The following is a description of a gene set: Human Gene Set: WP_PEPTIDE_GPCRS Peptide GPCRs species: Homo sapiens, and this is the list of marker genes: SSTR3, GALR3, CXCR2, AGTR2, OPRL1, TSHR, NTSR2, FPR1, MC5R, CCR8, GRPR, AVPR1B, MC3R, GNRHR, MC1R, CCKBR, NPY2R, CXCR3, AVPR1A, CCR7, TACR3, HCRTR1, C5AR1, SSTR2, CCR6, BDKRB2, AVPR2, FPR3, NPY5R, OXTR, CCR5, CXCR1, ACKR1, TACR2, LHCGR, BRS3, CCR1, NMBR, OPRM1, TRHR, OPRK1, FPR2, OPRD1, SSTR1, CCKAR, TACR1, EDNRA, NPY1R, CCR10, SSTR5, SSTR4, CXCR5, GALR2, MC4R, CCR2, ATP8A1, NTSR1, MC2R, GALR1, GHSR, HCRTR2, BDKRB1, TAC4, C3AR1, CCR9, EDNRB, NPY4R, CXCR6, CCR3, AGTR1, CX3CR1, CXCR4, FSHR, CCR4, NPY6R